The following is a description of a gene set: studied in species Homo sapiens Syncope Syncope is a syndrome in which loss of consciousness is of relatively sudden onset, temporary (usually less than 1 to 2 minutes), self-terminating, and of usually rapid recovery. Syncope leads to a generalized weakness of muscles with loss of postural tone, inability to stand upright, and loss of consciousness. Once the patient is in a horizontal position, blood flow to the brain is no longer hindered by gravitation and consciousness is regained. Unconsciousness usually lasts for seconds to minutes. Headache and drowsiness (which usually follow seizures) do not follow a syncopal attack. Syncope results from a sudden impairment of brain metabolism usually due to a reduction in cerebral blood flow. Human Gene Set: HP_SYNCOPE, and this is the list of marker genes: ABCC9, NPPA, CACNA1D, KCNJ2, KCNJ11, RANGRF, HCN4, MYBPC3, TNNI3, TRPM4, SCNN1A, KCNE5, KCNE3, SCN4B, CACNA1C, KIF20A, SLC4A3, CASQ2, TNFSF4, AKAP9, JUP, HLA-DQB1, KCNQ1, NTRK1, SMARCE1, SLMAP, ABCC8, MOG, CALM2, KIT, ATP13A3, SCN3B, SLC12A3, ANK2, CACNA2D1, GNB2, PSEN2, SCN1B, ZNF365, CAV3, PIK3CA, THPO, GATA4, TBX20, PDGFB, NOTCH2NLC, GPD1L, TRDN, ELN, MPL, KCNE1, HNF1A, TNNT2, CLCNKB, ASXL1, RNF125, ACTC1, TERT, MGAT2, SUFU, KCNJ5, NUP155, KCNA5, NKX2-5, GATA6, GJA5, MYL4, LMNA, JAK2, PRKAG2, TBX5, MYPN, SCN10A, UCP2 (NCBI Gene Id 7351), TTN, LAMP2, TECRL, SCN2B, MYH6, SCN5A, KCND3, P2RY11, COQ2, SMARCB1, RYR2, CITED2, DBH, HCRT, TRAF7, SMO, PITX2, CTSH, KCNJ3, HLA-DRB1, CALM1, GATA5, SEMA3A, PSEN1, TNNC1, BAP1, AKT1, PKP2, CACNB2 (calcium voltage-gated channel auxiliary subunit beta 2), DSP, FLNC, KCNJ8, KCNH2 (potassium voltage-gated channel subfamily H member 2), NKX2-6, NOS1AP, MYOZ2, TLL1, CALM3, BVES, KCNE2, ALG10B, DSC2 (NCBI Gene Id 1824), SNTA1, SRSF2, TET2, NF2, SLC6A5